The following is a description of a gene set: Human Gene Set: GOBP_VASCULAR_WOUND_HEALING studied in species Homo sapiens Blood vessel formation when new vessels emerge from the proliferation of pre-existing blood vessels and contribute to the series of events that restore integrity to damaged vasculature., and this is the list of marker genes: VEGFA, MIR34A, SERPINE1, HTN1, HPSE, NDNF, TAFA5, MIR1298, MIR200B, ADIPOR2, SMOC2, XBP1, TNF, MIR451A, FOXC2, SLC12A2, TNFAIP3, CD34, GATA2, VEGFB, MCAM, KDR, ALOX5, NPR2